The following is a description of a gene set: from publication Tabula Muris Consortium (PMID 32669714) Mouse Gene Set: TABULA_MURIS_SENIS_MARROW_LATE_PRO_B_CELL_AGEING studied in species Mus musculus, and this is the list of marker genes: Rps7, Cox4i1 (NCBI Gene Id 12857), Atp5pd, Park7, Adrm1, Arl6ip4, Hes6 (hairy and enhancer of split 6), Atg101, Mrpl57, Swi5, Atp6v0b, Psmb6, Babam1, Pfdn6, Tspo, Tmsb10, Lamtor2, Ngp, Mrpl17, Ostf1, Klf13, Rpl27a, Pfn1, Cdc37, Ppp1r35, Rps5, Jund, Sdc4, Eif3i, Slc66a3, Cuta, Ndufa8, Tmed10, Blvrb, Arpp19, Grcc10, Rpl13, Atp5f1d, Necap2, Tle5, Arpc3, Col1a1, Psme2 (NCBI Gene Id 19188), Retnlg, Cd79a, Etfb (electron transferring flavoprotein, beta polypeptide), Cacybp, AW112010, Tpt1, Manbal, Srp14, Eef1d, Sdhc, Eif6, Ypel3, Ptpn18, Rplp2, Slc3a2, Bsg, Igtp, Cisd3, Tex261, Psmb8, Atp5mg, Atp5if1, Rpl24, Sdc1, Prelid1, Cox8a, Dmac1, Mrpl43, Chchd10, Jtb, Ndufa13, Dnajc7, Tbcb, Rps8, Hint1, Camp, Rhoj, Rabac1, Pebp1, Ap2s1, Aurkaip1, Trp53i11, Mrpl58, Aimp1 (aminoacyl tRNA synthetase complex-interacting multifunctional protein 1), H2-Aa, Laptm4a, Lsm2, Rps15, Edem1, Rps3, Tssc4, Tm2d2, Cope, Bloc1s1, Emc10, Spi1, S100a6, S100a9, Ndufb11, Tomm6, Elof1, Ssr4, Zbp1, Kcnn4, Sin3b, Tmem234, Tmbim6 (NCBI Gene Id 68309), Cfl1, Nme1, Gpx4 (NCBI Gene Id 625249), Psme1, Rps14, Spint2, Ppp1r11, Stmp1, Plp1, H2aj, Ndufs6, Mea1, Cotl1, Rpl18, Nabp2 (NCBI Gene Id 69917), Rps11, Txn2, Tma7, Dgcr6, Car2 (NCBI Gene Id 99551), Znhit1, Tmsb4x, Npc2, Hp, Ifnar2 (NCBI Gene Id 194555), Pkm, Fam89b, Ndufv3, BC004004, Eif3g, Ier3ip1, Psmd4, Tmbim4, Rps9 (NCBI Gene Id 76846), Reep5, Fkbp2, Rnasek, Smdt1, Arpc1b, Snrpc, Pold4, Uqcrh, Plaat3, Rpl27, Ndufb9, Calm1, Elob, H2bc4, Dynlrb1, Eif3k, Bbln, Edf1, Pfdn5, Ssbp4, Nfkbib, Ift27, Gadd45gip1, Phb2, Mrpl54, S100a8 (S100 calcium binding protein A8 (calgranulin A)), Ptma, Prr13, Arhgdia, Hsd11b1, Exosc5, Lrp10, Ndufb8 (NADH:ubiquinone oxidoreductase subunit B8), B2m, Drap1, Selenok, Csnk2b, Dad1, Fau, Myl12a, Map1lc3b, Mrps12, Selenow, Chmp2a, Sp140l2, Pafah1b3, Gtf2h5, Lsm4, Gmfg, Cst3, Ccnd2, Naxe, Tmem160, Rrp1, Rpl11, Vamp8, Stmn1, H2-M3, Mpc2, Nol7, Uqcrq, Ccdc124, Rpl17, Ndufs3, Myl6, Rps18, Scand1, Map2k2, Dctn3, Prdx5, Epcam (epithelial cell adhesion molecule), Eef1b2, Mlf2, Slpi, Gpx1, Sf3b4, Rpl13a, H2ac18, Mrps24, Ftl1, Psmb5, Psma7, Dok3, Syf2, Rnaseh2c, Ninj1, Nedd8 (neural precursor cell expressed, developmentally down-regulated gene 8), Pgls, Fth1, Akt1s1, Ndufb7, Nme2, Atp6v1f, Tmem176a, Sar1a, Lyz2, Mrpl12, Ndufb10, Lmo4, Rplp1, Selenom, Cdk2ap2, Alad, Rps10 (ribosomal protein S10), Psmb4, Lcn2